The following is a description of a gene set: studied in species Mus musculus Mouse Gene Set: GOBP_ANTERIOR_POSTERIOR_AXON_GUIDANCE The process in which the migration of an axon growth cone is directed to a specific target site along the anterior-posterior body axis in response to a combination of attractive and repulsive cues. The anterior-posterior axis is defined by a line that runs from the head or mouth of an organism to the tail or opposite end of the organism., and this is the list of marker genes: Dcc, Unc5a, Ntn1, Lhx9, Unc5b, Unc5c